Given this list of marker genes Parn, Cnot1, Cnot6l, Toe1, Cnot2, Cnot8, Pan3, Pde12, Noct, Pnldc1, Pan2, Cnot6, Cnot7, here is a description of the gene set: Mouse Gene Set: GOMF_POLY_A_SPECIFIC_RIBONUCLEASE_ACTIVITY Catalysis of the exonucleolytic cleavage of poly(A) to 5'-AMP. species: Mus musculus